Given this list of marker genes KIAA0753, TBCE, SIN3A, NDN, TBX2, AIP, FOXH1, ZIC2 (Zic family member 2), SMC1A, WDR4, LHX4, KCNJ11, IARS2, DYRK1A, PWAR1, GNB2, ZNF148, ACP5, TMCO1, POR, MAGEL2, KMT2D, POLR3A, PREPL, NSUN2, SNORD116-1, HERC2, NNT, KATNIP, TXNRD2, POMC, POLR3GL, DISP1, ADAT3, SUFU, GNAS, NODAL, LHX3, PROP1, HESX1, MKRN3, ABCC8, PRKAR1A, MC2R, SLC7A7, NFKB2, SHH, BRCC3, GLI2, PCSK1, SMO, RFWD3, KANSL1, SRD5A3, GLI3, ARMC5, SBDS, GHSR, OCA2, HSD3B2, PITX2, STAG2, PWRN1, SNRPN, EIF2S3, PLCH1, SIX3, BTK, TRAPPC11, SLC29A3 (solute carrier family 29 member 3), THOC2, BAP1, OTX2, VPS13B, TBCK, IGF2, GAS1, GH1, BPTF, LIG4, AKT1, FLNB, TGIF1, CHD7, TMEM67, POU1F1, AFF4, AAAS, WASHC5 (NCBI Gene Id 9897), RNPC3, PNPLA6, CDON, ARNT2, PTCH1, SMARCE1, STAR, FANCF, RRAS2, PSMD12, PIK3CA, CEP57, POLE, NPAP1, MADD, STIL, ALMS1, TRAF7, STX16, GMPPA, DLL1, CDH23, DNAJC21, TERT, YY1, GRM7, ESCO2, SOX11, CYP17A1, NF2, CDKN1C, LEPR, NHLH2, CTSK, PDGFB, CRIPTO, FGFR1, GHRHR, GRB10, SMARCB1, STAT5B, UCP2, FEZF1, MRAP (melanocortin 2 receptor accessory protein), MPDU1, TP63, GMNN (NCBI Gene Id 51053), FGF8, NKX2-1, FOXA2, RBM28, SOX3, KDM6A, MED12, MEN1, SNORD115-1, EFL1, KMT2A, ADNP, ZNF462, MAP2K2, HNF1A, POU3F4, KDM1A, here is a description of the gene set: species: Homo sapiens Human Gene Set: HP_ABNORMAL_RESPONSE_TO_ENDOCRINE_STIMULATION_TEST Abnormal response to endocrine stimulation test An anomalous response to a test that is designed to probe the function of the endocrine system.